The following is a description of a gene set: Cytokines mediate cell-cell communication in the immune system and represent important therapeutic targets. A myriad of studies have highlighted their central role in immune function, yet we lack a global view of the cellular responses of each immune cell type to each cytokine. To address this gap, the authors created the Immune Dictionary, a compendium of single-cell transcriptomic profiles of more than 17 immune cell types in response to each of 86 cytokines (>1,400 cytokine-cell type combinations) in mouse lymph nodes in vivo. A cytokine-centric view of the dictionary revealed that most cytokines induce highly cell-type-specific responses. For example, the inflammatory cytokine interleukin-1β induces distinct gene programmes in almost every cell type. A cell-type-centric view of the dictionary identified more than 66 cytokine-driven cellular polarization states across immune cell types, including previously uncharacterized states such as an interleukin-18-induced polyfunctional natural killer cell state. Mouse Gene Set: CUI_MIGDC_IFNL2_RESPONSE_UP from publication Cui A, Huang T, Li S, Ma A, Pérez JL, Sander C, Keskin DB, Wu CJ, Fraenkel E, Hacohen N (PMID 38057668) Genes positively differentially expressed in cell type: MigDC (migratory dendritic cell) upon treatment with cytokine: IFN-λ2 in mouse lymph nodes in vivo. species: Mus musculus, and this is the list of marker genes: M6pr, Tmbim6, Isg15, Tmsb10, Dock11, Ifi27l2a, Rnf213, Ndufa11, Pdia3, Parp9, Nt5c3, Ifitm3, Shisa5 (NCBI Gene Id 67794), Trim30a, Slfn2, Ifit1, Stat1